Given this list of marker genes Dtx1, Ubb, Dll1, Psenen, Wwp2, Psen1, Dll4, Rps27a, Elf3, Snw1, Dtx4, Egfr, Notch3, Ep300, Dtx2 (NCBI Gene Id 74198), here is a description of the gene set: part of: Signal Transduction This event has been computationally inferred from an event that has been demonstrated in another species.<p>The inference is based on the homology mapping from PANTHER. Briefly, reactions for which all involved PhysicalEntities (in input, output and catalyst) have a mapped orthologue/paralogue (for complexes at least 75% of components must have a mapping) are inferred to the other species. Reactome Pathway: Signaling by NOTCH studied in species Mus musculus electronically inferred by orthology from the curated human pathway